The following is a description of a gene set: species: Mus musculus Mouse Gene Set: MIR_3098_3P Genes predicted to be targets of miRBase v22 microRNA mmu_miR_3098_3p in miRDB v6.0 with MirTarget v4 prediction scores > 80 (high confidence targets). from publication Chen Y, Wang X (PMID 31504780), and this is the list of marker genes: Hdac11, Syt14, Tent5a, Dyrk1a, Chst7, Clns1a, Bclaf3, Ablim1, Mmp21, Rnf24, Tgif2, Arf4, Zmiz1, Fam216b, Pnn, Kat6a, Neurod1, Gatad2a, Gpr165, Snx4, Dhcr7, Serf2, Cdh4, Il1r1, Plxna4, Zpbp2, Dkk2, Dzank1, Gapvd1, Tnfrsf19, Tmem150a, Pacsin2 (protein kinase C and casein kinase substrate in neurons 2), Zdhhc15, Psmd5, Mga, Fbxo32, Rbbp6, Bod1l, Prrt3, Ptpn2, Ccdc25, Ube2d3, Duoxa1, Fam20c, Aak1 (NCBI Gene Id 97341), Atrn, Prpf19, Cycs, Morn4, H13, Fank1, Xylb, Fancl, Rcc1, Ntrk2, AW554918, Stil, Ikzf3, Smad2, Sorbs2, Sertad2, Ypel2, Tmem64, Dlgap1, Slamf7, Tut4, Zfp11, Zfp395, Ms4a3, Caskin1, Chst11, Fhl1, Ermn (ermin, ERM-like protein), Rictor, Ubr3, Zcchc17, Gkap1, Orc1, Mdh1, Kcnq5, Tmem245, Irs1 (insulin receptor substrate 1), Frmpd4, Dcx, Idi2, Ppm1n, Creg2 (NCBI Gene Id 263764), Ttc17, Hdx, Hectd2, Zhx2, Steap2, Ctnnal1, Patl1, Mxi1, Rmnd5a, Ubash3b, Anapc10, Ptp4a2, Man1c1, Pllp, Ogt, Dlg3, Spink5, Klhl2, Nnat, Ubqln1, Eif4b, Primpol, Lsm2, Slain2, Ralbp1, Ndc1, Slc10a1, Kpna4, Ddi2, Or5k1, 1110038F14Rik, Emc4 (ER membrane protein complex subunit 4), Ghitm, Myadml2, Sh2b3, Msrb3, Slc37a3, Tmem106a, Set, Nav1, Paqr5, Nr6a1, Fzd3, Gtf3c4, Psmc6, Grik3, Abl2, Epha7, Phldb1, Plppr4, Tom1l2, Eif4g2, Plscr4, Tns3, Sox6, Zic2, Camk1d, Tmem216, Rc3h1, Krtap2-4, Medag, Phactr2